The following is a description of a gene set: from publication Chen Y, Wang X (PMID 31504780) Genes predicted to be targets of miRBase v22 microRNA hsa-miR-30a-5p in miRDB v6.0 with MirTarget v4 prediction scores > 80 (high confidence targets). studied in species Homo sapiens Human Gene Set: MIR30A_5P, and this is the list of marker genes: PAWR, NFATC2, TTLL2, TMEFF1, STOX2, MBTPS2, OMG, GABRB1, NUS1, PHF13, PLIN3, ELOVL5, UBE2I, MAP3K5, DIPK2A, BRWD1, LHX1, LINC03034, DSG2 (desmoglein 2), TSPAN2, SEMA3A, MAPK8, MED12L, JADE3, DDX59, AFF4, MCF2L, RAVER2, ARID5B (NCBI Gene Id 84159), WDR44, MEIOB, YPEL5, CNOT6, CPEB3 (NCBI Gene Id 22849), BNC1, ERLIN1, EPG5, CYB561, SEMA6B, PRKAA2, MAB21L1, SCYL3, MAML1, MAN1A2 (NCBI Gene Id 10905), PDXDC1, SSH2, LPP, MAST3, YTHDC1, PRPF40A, UBN1, FOXG1, PPP3CB, MAP3K13, PLPPR4, P4HA2, SOCS6, AZIN1, ZBTB41, TMEM229A, ATRN (NCBI Gene Id 8455), TBL1XR1, SMDT1, SLC7A10, PTPN13, ZNF519, PPP3R1, RAI14, IDE, VAT1, LARGE1, GOLGA6C, FNDC3A, BCL10, EPC2, UBE2J1, PGP, SEC61A2, VKORC1L1, XPO1, BNC2, ZCCHC3, UBE3C, NF1, CERS6, SRSF10, FRZB, RASA1, ZNF507, PHTF2, SNX33, KLF9, FRMD6, GNAI2, TENM3, CDCA7, FAM110B, NAPG, RNF122, NDUFC2, CAMK2N2, CEP350, KCTD8, SOX13, SAP30BP, ANXA2R, TMOD2, CCDC120, ANKRA2, VIM, FLVCR1, TMEM87A, SAMTOR, MRPL19, MIER2 (MIER family member 2), CCNT2, SAMD4A, ZNF382, TNIK, RUNX2, FHIP2A, CCDC97, MARCHF8, PGM1, GFPT2, CSNK1G1, TENM1, ATG12, LRRC8D, CEP170 (centrosomal protein 170), ADAM12, CUL2, LIN28B, PER2, ZNF711, ABHD10, CNKSR2, PIK3CD, NSG1, SNX8, ROR1, MEX3C, SMAP1, ADGRA3, BAHD1, BCL9, RBM12, BRD10, LOX, LPGAT1, ITGB3, AVEN, CCDC6, ELOVL2, NTNG1, OSBPL8, HOXA1, PI4K2B, ST8SIA4, STIM2, LYRM7, ADAM19, YPEL2, YY2, IRF4, RNF157, AGO3, EDC3, PLAGL2, SAMD8, DENND1B, SH3RF1, SLC25A36, RARG, KLF12, SCN8A, ZNF608, KMT2A, CHST2, UBAC1, WIPF3, RAP2C, RAB15, ARAF, YAF2, TSEN15, BRAP, ATP2A2, LRRC8C, FIGN, LHX8, PDSS1, RHEBL1, KCNA4, ALG10, RAPGEF2, PPP4R4, SCN2A, FAM43A (NCBI Gene Id 131583), ELAVL2, ANO4, COL9A3, KLF8, LGI1, DLL4, RRAD, FAM91A1, KDM3A, OTUD4, SLC35C1, CSAD, STX2, ANKRD17 (NCBI Gene Id 84177), RAP1B, PLEKHO2, PDS5B, CERT1, CPNE8, TLL2, RAB2A, NAA25, PDE7A, GRM3, NKX2-2, OSTM1, PHACTR2, ATXN1, TAB3, KXD1, ATG5, SNX18, CTHRC1, PRLR, TTC8, KIF11, CHD7, ACVR1, ZFAND1, PROSER1, BCL2L11, OVOL1, MXRA5, SLC25A34, MZT1, ZNF644, AFAP1L2, DLGAP1, HNRNPUL2, CBLB, EXTL2, INPP4A, FOXD1, SRGAP3, RRAS2, CCDC117, CALCR, SACS, NLGN1, PSD3, ACTR1A, TENT5A, PLEKHM3, SH3PXD2A, TENT2, COL13A1, DCTN4, CACHD1, MAP3K2, IRF2BP2, NECAP1, MBOAT1, CRACDL, CAPZA1, GALNT1, PRICKLE1, KLHL28, PAPOLA, CCNA1, HIVEP1, LRRC17, FBXL17, CADPS, ZNRF1, SCML1, USO1, KLF10, SOCS1, NAP1L2, ITPK1, PPP1R9A, TMCC1, RALGPS1, NEFL, ACTR3C, ESCO1, PTPDC1, RARRES1, GRIN2A, PCMTD2, SEPTIN7, LCLAT1, NAALADL2, PLPP6, TULP4, MSI2, WDR82, PHIP, MKRN3, OTUD6B, GLCCI1, NDEL1, TUT7, MAST4, DOK5, TP53INP1, DSTYK, FKBP3, ACTC1, NHLH2, KSR1, RAPH1, RASD1, UGT2A3, MFHAS1 (NCBI Gene Id 9258), CHL1, HDAC9 (NCBI Gene Id 9734), PALM2AKAP2, FZD3, TAOK1, DOLPP1, XPR1, LRRK2, LIFR, EML1, RAB38, PPTC7, ZFY, DNAJC25-GNG10, YTHDF3, RPRD1A, CCNJL, WDR7, KIAA1549, ZBTB44, GMNC, ATF1, NEUROD1, MAP6, FAM13C, ARK2C, CAMK4, EFNA3, CNST, ARID4A, GARRE1, CDC37L1, MYO1H, IDH1, CDH20, LIN28A, MBNL3, SCARA5, SDAD1, PSMD7, BCOR, STK39 (NCBI Gene Id 27347), JPH4, TOX, CARF, CAND1, ARID1A, SEPTIN8, YOD1, WDR64, NUFIP2, KIAA0408, FBXO34, MAP3K7, SIX4, RASA2, GRIA2, SEC22C, NAV3, MARCHF6, CFAP97, SUV39H2, FGD6, DPYSL2, CLOCK, NCALD, NHS, SCEL, TEPSIN, ELAVL4, ITGA8, TMEM170B, JAKMIP2, PON2, PDGFRB, BCL11B, SKP2, EED, MMD, REEP1, PRG4, R3HDM1, KLHL20, CEP41, SLC12A6, GLDC, SOCS3, ATL2, TM4SF1, NRG3, TLCD4, HCFC2, ZNF704, LIMCH1, GNPDA1, ZFAND5, ERG, SLC6A6, BDP1, SCN3A, IQCB1, NEURL1B, GDE1, TRIO, ZBTB6, SETD7, PAXBP1, CSGALNACT1, MAP4K4, ERRFI1, RALGDS, TMEM181, KMT2C, STT3B, STX16, USP48, ZCCHC2, FBXL20, NT5E, STXBP5, TBC1D10B, MAFG, PLA2G12A, TNRC6B (trinucleotide repeat containing adaptor 6B), UBN2, MYBL2, SCN1A, ME1, RAPGEF4, NEDD4, SLCO6A1, GALNT2, MROH9, SETD5, RUNDC3B, CRKL, HBS1L, COL25A1 (NCBI Gene Id 84570), TNRC6A, DDAH1, PPP1R18, PNPLA1, INO80D, VAT1L, SLC35F1, SNTB2, RAB8A, PRDM13, IRX4, HACE1, KCTD16, DNAJC13, PEX5L, SLC4A7, TBC1D15 (NCBI Gene Id 64786), SNAI2, PNKD, S100PBP, KRAS (NCBI Gene Id 3845), UNC5C, NUCKS1, SLC35A3, FBXO45, PPID, RORA, FNIP2 (folliculin interacting protein 2), ADRA2A, DCUN1D1, IFNAR2, PAX3, SP4, RTN4R, TASP1, MYO5A, CHIC1, SLC9A8, GNG10, C4orf19 (chromosome 4 open reading frame 19), GNA13, CCNK, TWF1, ADAMTS6, FAM133A, CNOT9, RFX6, ZXDA, IRS1, OGA (NCBI Gene Id 23375), PRDM1, STAG2, CCDC43, ZNF286A, GPR19, BRWD3, DDIT4, MAP3K21, NR6A1, ZBTB11, JOSD1, SIX1, PPP3CA, RGS8, ARHGEF6, TRPM7, LMBR1L, CYP24A1, AVL9, TBC1D2B, EDNRA, CACNB2, CECR2, SHOC2, LRFN2, SEC24A, PGM3, RFX7, CMTM4, ZEB2, AP4E1, EPB41, PFN2, LMLN (NCBI Gene Id 89782), DMXL2, ZNF518A, SCN9A, POLR3E, TMEM87B, FBXO32, DACT1, EDEM3, PIP4K2A, PIGA, SH2B3, CYP3A5, CFL2, ADAM9, ATOSA, EEF1A1, TDG, LCORL, EML4, P4HA1, GAREM1, ATP2B1 (NCBI Gene Id 490), RUNX1, GPT2, MEX3B, CSNK1A1, FAM13A, LYPLAL1, PRUNE2, PDCD10, FRMPD1, EEA1 (NCBI Gene Id 8411), GOLGA4, PAPOLB, PTP4A1, TAF4B, PPARGC1B, TNRC6C, LYN, MLXIP (MLX interacting protein), SYNGR3, SLC30A4, STK17B, ADGRL3, MYH11, DCUN1D3, MFSD6, RAB23, HIPK2, NR5A2, PTGFRN, MPZL3, PPP1R1C, DLG5, SNX10, PPP1R2, GCLC, ABL1, USP37, NCAM1, SLC5A3, GIGYF2, OXR1, LMBR1, CD2AP, RAB32, B3GNT5, EXOC6, CBFB, ASB2, IL36RN, GOLGA8A, ESPN, CBX2, FAM210B, PTPN2, CELSR3, MTDH, SPOCK3, GATM, CAPN5, SRSF7, SDK2, NADK, MIER3, SLC35F3, TM4SF20, TTLL7, TFDP1, NRIP1, RIMBP2, SLC38A2, ANKHD1, TCIM, ARHGAP26, BRD1, TRIM13, DLGAP4, GRM5 (NCBI Gene Id 2915), ASB3, TRAPPC14, MTCL2, E2F7, SOX9, SLC25A21, KPNA6, ALG10B, LRP6, SPAST, NFIB, BECN1, RAB27B, PCDH17, CPSF6, TNXB, ZPBP2, PIP4K2B, CEP15, C14orf28, RAD23B, IL1RAPL2, JDP2, EIF5A2, CARS1, NR4A2, ERICH3, GALNT7, HYCC2, RTN4IP1, CCNE2, LRRC40, WASHC4, FAM199X, TTBK1, DPY19L1, IGF2R, CHST1, GLI2, SNAI1, VPS26B, PICALM, ZMYND8, ELL2, NFAT5, IP6K3, ZBTB18, C9orf72, THAP12, RAB4B, FAP, PPP1R12A, STRIP1, DPY19L3, TOGARAM1, PIEZO2, ITGA6, ARMH3, REEP3, KCTD7, MAT2A, DGKH, ADRA1D, UBE2V1, ADGRA2, SNX16, UBE2V2, CAMK2D, GSKIP, SEC23A, GRB10, SHISA3, GOLGA1, CAMKK2, GPCPD1, RTKN2, ELMOD2, CHMP2B, BNIP3L, CALU, RHOB, LRRC8B, CDK12, ADAMTS9, SPEN, ZNF22-AS1, MIA3, PDE4D (NCBI Gene Id 654081), PCGF5, MARCHF4, DESI2, NFATC3, FAM229B, STAC, RNF220, ADO, ZNF521 (zinc finger protein 521), MARK1, STK35, FAM83F, ZFC3H1, SLC35B4, PAAF1, FLVCR2, ADAMTS3, DNMT3A, WWP1, SYPL1, GJA1, VOPP1, MEOX2, PPARGC1A, KIF16B, DOCK7, HIC2, NEFM, SLC38A7, SMAD1, ZDHHC17, ASB4, CHD1, WIPF1, ABCC9, SCAF4, NUP93, GMEB2, ADAM22, A1CF, KATNBL1, RHD, ARHGAP29, APBA1, CAMK2N1, B4GALT6, ZNF280B